The following is a description of a gene set: from publication Chen Y, Wang X (PMID 31504780) Genes predicted to be targets of miRBase v22 microRNA mmu_miR_495_3p in miRDB v6.0 with MirTarget v4 prediction scores > 80 (high confidence targets). Mouse Gene Set: MIR_495_3P species: Mus musculus, and this is the list of marker genes: Osbpl6, Abhd13, Ctnnd2, Elf2, P2ry1, Bcat1, Pak3, Bend4, Cyp2u1, Tspan31, Nfib, Uqcc4, Tfam, Zfand1, Nlgn2, Ssx2ip, Cyria, Nat14, Cdh2, Zfp422, Zfp462, Rrp1b, Pbx2, Cadps2, Gm20815, Wdr25, Tmx4, Semp2l2a, Hspa5, Six4, Gria3, Nmt2, Cep15, Il19, Tmppe, Matn1, Fat1 (NCBI Gene Id 76752), Rflnb, Ran, Tent5a, Cln8, Nip7, Fbxo43, Zfp719, Cpeb3, Tcstv3, Neurod6, Tcstv2c, Scn3a, E4f1, Ranbp1, Ints12, Nup107, Rimbp2, Sin3b, Nhlh2, Rnf44, D16Ertd472e, Far1, Tmub2, Pogk, Apol10b, D1Pas1, Grm5 (NCBI Gene Id 14820), Sgpp1, Pde4c, Clcn5, Tmem263, Upf1, Espnl, Il17re, Kif1c, Plekhm3, Selenoi, Extl1, Elovl7, Mphosph9, Tbx3, Gm5148, Stxbp6, Prkd3, Akap6, Ranbp6, Tmem88b, Col19a1, Ct55, Psme3, Sec22b, Samd4, Gpr22, Zfp280c, Mylk4, Nufip2, U2surp, Sema3c, Atl2, Pafah1b1, Adam17, Syt15, Noc2l, Cbx5, Ccdc34, Nop16, Tcstv2b, Ttc12, Dennd6a, Pttg1, Tet1, Ppm1k, Macf1, Nfat5, Gdpgp1, Ccdc93, Hsf5, Rai2, Tmed9, Tyms, Plcb3, Copb1, Arl13b, Fzd6, Arid5b, Ddhd1, Arl8a (ADP-ribosylation factor-like 8A), Tbc1d30, Aard, Dtx3l, Rbpj, Scd4, Cd200r4, Tsen34, Enah, Igfbp5, Bnip5, Chml, Mrgprb2, Vav2, G2e3, Hykk, Cxcr4, Lrrc58, Lsm6, Ccbe1, Bcl2l12, Mtf2, Twf1, Sdr16c5, Tmtc1 (NCBI Gene Id 387314), Gtf3c3, Hook3, Glis3, Dnmt3a, Canx, Bdnf, Shisa9, Ctsc, Zfp26, Bcl11a, Scai, Hspbap1, Fli1, Fam187a, Fcgr4, Zfp292, Slc35a5, Trim32, Cebpg, Agl, Msi2, Syn2, Kmt5b, Lrba, Erich5, Asb8, Riok3, Champ1 (chromosome alignment maintaining phosphoprotein 1), Lrrc38, Kras, Ccnjl, Kpna2, Naa16, Rora, Shisa2, Ccdc126, Atxn7, Synpr, Prkx, Fut9, Nuak2, Zhx3, Trim33 (NCBI Gene Id 99609), Mia3, Nap1l1, Dstyk, Lgmn, Mafb, Lrp6, Zfx, Scn8a, Bloc1s2, Rnf4, Rhobtb1, Terf1, Trip12, Gm21083, Bicd1, Phlpp1, Slc22a23, Ppih, Speer4e1, Uri1, Celf1, Klhl15, Tcstv7a, Kcnk3, Sgk1, Pkp4, Rbm20, Socs4, Naa12 (NCBI Gene Id 117903916), Gpm6a, Rictor, Mrfap1, Fkbp5, Gab3, Gm21190, Ddx39b, Orai2, Gna13, Tcstv2a, Grb2, Dynlt3, Marf1, Smc6, Crebzf, Dnajc6 (DnaJ heat shock protein family (Hsp40) member C6), Utp4, Ecm2, Fam3c, Prickle2, Nbeal1, Neu3, Ptpra, Fgf9, Prickle1, Hbegf, Homer2 (homer scaffolding protein 2), Zfp518a, Nectin3, Gm10377, Scg2, Sppl2a, Bloc1s3, Csnk1a1, Fbxl14, Fthl17e, Zbtb44, Adrb2, Hps3, Gfra2, Lonrf3, Slc25a51, Fstl1, Tgfb2, Cpeb4, Actr6, Cds1, Mdga2, Kif5c (NCBI Gene Id 16574), Abca8a, Pabpc5, Mapk6 (mitogen-activated protein kinase 6), Tpbg, Impa1, Htr1a, Cd44, Onecut3, Yes1, Septin8, Parp11, Med1, Apod, Braf, Ldlrad3 (low density lipoprotein receptor class A domain containing 3), Slc8b1, Clock, Tgif1, Slf2, Tm9sf3, Fign, Ssh2, Arhgap28, Chd9 (NCBI Gene Id 77692), 1700001F09Rik, Eml4, Apbb2, Elmod2, Cdk6 (NCBI Gene Id 330039), Kdm4a, Atrn, Wwtr1, Irf1, Dpp8 (NCBI Gene Id 76430), Mboat7, Satb1, Elp2, Jade1, Adra1a, Sox5, Plaur, Thumpd1, Ddx19b, Elavl1, Cts8, Sash1, Celf2, Hyal4, Speer4c1, Ebf2, Slc16a1, Nab2, Cxxc4, Fgf10, Dmp1, Tcf4, Gtf2a1, Camk2g, Syt6, Ube4a, Prdm1, Cand1, Wdtc1, Kcnh5, Wnt5a (NCBI Gene Id 77565), Map3k4, Azi2, Hycc2, Sycp3, Atp2b2, Sgcb, Tnrc6b, Oprm1, Zrsr2, Cutal, Zfhx3, Myod1, Armc2, Zmat3, Snapc1, Mllt11, N4bp2l2, Vezf1, Vkorc1l1, Bdp1, Rb1cc1, Paqr6, Cbln4, Slc25a46, Sntb2, Hoxd9, Grk3 (G protein-coupled receptor kinase 3), Fbxo28 (F-box protein 28), Myo1b, Megf10, Zfp512, Abraxas1, Prkaa2, Luc7l, Frmd4a, Zbtb34, Afap1, Prelid3b, Ptpn2, Faf1, Maoa, Zfand4, Gpat3, Arih1 (ariadne RBR E3 ubiquitin protein ligase 1), Tbl1xr1, Lclat1, Slc15a1, Washc4, Naaladl2, Mllt1, Onecut2, Elavl4, Rsbn1l, Mapk10, Cdc42ep4, Lhx2, Ckap4, Naa30, Mex3a, Marveld1, Tcstv5a, Gmip, Ttll7, Trmt9b, Pcdh18, Setx, Gm5127, Arrdc3, Map4, Exoc5, Ddx3x, Tcerg1, Bcl11b, Kdm1a, Snurf, Phf14, Calml3, Pcdhb22, Ap3m1, Smc5, Osbpl8, Acsf2, Gsk3b, Parpbp, Ugcg, Hsp90aa1, S1pr3, Foxp2, Slc10a2, Thsd7a (NCBI Gene Id 671480), Nrxn3, Pou3f1, Zmym5, Fthl17a, Ctso, Map3k2, Ap1g1, Dennd2c, Mageb3, Mindy2, Ctnnd1, 4921517D22Rik, Fut11, Foxo1, Szrd1, Zbtb7a, Tardbp, Kalrn, Preb, Ctnna3, Pcyox1l, Ppp1cb, Zbtb21, Epb41l2, Prr7, Paqr9, Ccdc92, Synpo2, Satb2, Pcdh9, Arfgef1, Polr3b, Nr6a1, Get1, Notch1, Trim35, Skint7, Myt1l, Zmat1, Tsc22d3, Poglut3, Jarid2, Trim21, Hoxd11, Zfp113, Entpd4, Ado, Tfap4, Gse1, Eif5a2, Rmnd5a (required for meiotic nuclear division 5 homolog A), Dtwd2, Rbm12, Akap5, Ythdc2, Boc, Tcf7, Stxbp5 (NCBI Gene Id 78808), Ythdc1, Tcp10c, Pcdhb16, Mark2, Yipf6, Entpd7, Fam227a, Rab18, Poldip3, Fpgt (NCBI Gene Id 75540), Slc7a2, R3hdm2, Sall1, Otud7b, Vwc2l, Ercc6, Mef2c, Gpr107, Thbs2, Dmrt1, Dars1, Eif2b1, Tulp4, Edem3, Kmt2a, Pde8b, Etv1, Tgfbr3, Ppp1r27, Med18 (NCBI Gene Id 67219, mediator complex subunit 18), Cstf3, Arl5a, Septin11, Pank3, Kcnb2, Srgap1, Tnrc6a, Rpusd2, St3gal4, Cyp26b1, Pef1, Vsig10l, Zfp654, Iws1, Trio, Cdh1, Usf3, Plaa, Bclaf1 (NCBI Gene Id 72567), Ranbp3l, Aplp2, Hapln1, Gm10375, Zfp106, Rpgrip1l, Dach1, Timd2, Eif2s3x, Ddhd2, Aff2, Asah1 (N-acylsphingosine amidohydrolase 1), Ep300, Ccnd2, Itpripl2, Slc10a4, Dyrk1a, Prom2, Mtcl2, Hccs, Shroom2, Zfp799, Dap3, Hmgcll1, Tfdp1, Phtf2, Zbtb41, Csnk2a2, Galc, Rarb, Tasor, Nfe2l1, Fbxw7, Ssr3, Khdrbs2, Zfp84, Gbx2, Gm8267, Samd8, Prb1b, Cdk7, Mllt3, Serpinb10, Cdh20, Reep3 (receptor accessory protein 3), Mier1, Gpr183, Cacna1c, Paip1, Hipk1, Zmym2, Tmem170, Ldlr, Dgke, Cd55, Senp5, Maml3, Pex13, Slc35f1, Psd3, Unc45b, Septin7, Depdc1b, Rplp0, Esyt2, Piezo2, Larp4, Camk2a, Mtrr, Crebrf, Fndc3a, Vamp4, Dcun1d3, Ptk7, Dcaf17, Gabrb2, Mast4 (NCBI Gene Id 71635), Cdc37, Creb1, Zfp92, Itgav, Mbnl2, Myocd, Sirt6, Gna14, Shisal2b, Cdk17, Dock6, Tenm2, Snx12, Luzp2, Supt16, Atp6v1a (ATPase, H+ transporting, lysosomal V1 subunit A), Ptprf, Cflar, Nfya, Rab6b, Asb7, Arb2a, Gja8, Fubp1, Bend6, Zfp503, Dgkb, Slc10a4-ps, Wasl, Sec63, Dusp6, Gpr158 (G protein-coupled receptor 158), Igf1, Snrpb, Sh3bgrl2, Ift80, St8sia4, Ankrd13c, Fosl2, E130308A19Rik, Sgms2, Plch1, Fbxo3, Fam53c, Irf2bp2, Cops7b, Hepacam2, Rnf170, Nucks1, Adra2b, Rac2, Ino80d, Pbrm1, Pou4f1, Pdcd10, Med12, Ubtd2, Tnpo1, Ptpn21, Fbn2, Speer4d, Cnbp, Cpeb2, Ptf1a, Ift140 (intraflagellar transport 140), Htr4, Plek, Gm5796, Dusp10, Tdrd3, Tmem87b, Anapc1, Zfp955a, Kdm5a, Scfd1, Smim13, Casp3, Rere, Dicer1, Ipcef1, Zfhx4, Psg16, Fgfr1, Gm4894, Ddx46, Gpr12, Zfp329, Cacna1d, Mbtd1, Dusp1, Hoxa10, Arid1b, Pou3f2, Sgce, Scn7a, Tanc2, Arl14epl, Zdhhc21, Unc13c, Lrrtm4, Pcdhb19, Cdc14a, Phf8, Ooep, Pten, Spryd7, Prrg4, Prtg, Pou2f1, Tmed10, Traf3ip1, Rabgap1, Usp32, Hmgb2, Mvb12b, Zbtb26, Runx1t1 (NCBI Gene Id 12395), Itsn1, Reep1, Ythdf3, Rest, Zfp827, Esrrg, P2ry4, Trim6, Ppp6c, Actc1, Unc5c, Jun, Glipr2, Semp2l1, Ppfibp1, Ifnar2, Tceanc, Lnpep, Gngt1, Nras, Trps1, Acer3, Aebp2, B4galt7 (beta-1,4-galactosyltransferase 7), Zbtb37, Rab23, Ifnlr1, Rorb, Faxc, Ereg, Cnot6, Cep170, Zfp345, Znrf2 (zinc and ring finger 2), Cnnm3, Prpf18, Cbfb, Sgcz, Bri3bp, Msantd3, Xiap, Ralbp1, Tcstv4 (Tcstv family member 4), Il1rap (NCBI Gene Id 319228), Fsd1l, Kctd12, Runx3, Herpud2, Mrpl35, Lrrtm3, Ehf, Tirap, Bcl6b, Deptor, Syt14, Vps13d, Adamts5, Trim30a, Mgat2, Cmtm6, Metrn, Ywhab, Hnf4g, Dag1, Sfxn3, Kbtbd7, Arhgap19, Cox15, Ttc6, Ntng1, Alg6, Tbx18, Snx11, Mapk8